The following is a description of a gene set: studied in species Mus musculus Genes predicted to be targets of miRBase v22 microRNA mmu_let_7a_1_3p, mmu_let_7c_2_3p in miRDB v6.0 with MirTarget v4 prediction scores > 80 (high confidence targets). Mouse Gene Set: LET_7A_1_3P_LET_7C_2_3P from publication Chen Y, Wang X (PMID 31504780), and this is the list of marker genes: Zfp518a, Foxp1, Nbea, Cnnm4, Cntrob, Utrn, Srsf2, Sox9, Fbxo38, Il5ra, Usp32 (NCBI Gene Id 77025), Hacd2, Gpalpp1, Etl4, Pabpc4l, Lysmd3, Gp1ba, Gabrg1, Bnip2, Aqr (NCBI Gene Id 99376), Nr2f2, Thrb, Gnpat, Fgfr2, Cnot6l, Mblac2, Myct1, Asic4, Bmpr1a, Kpna3, Kdm7a, Rhot1, Man1a2 (mannosidase, alpha, class 1A, member 2), Plag1, Eea1, Tecrl, Ctu2 (cytosolic thiouridylase subunit 2), Lemd3, Mfsd1, Tns3, Sspn, Mdm4, Klhl2, Fa2h, Slc25a16, Taok1, Glcci1, Sh3gl3, Wdr26, Trpm7, Chd1, Ube2b, Atf2, Cacna2d1, Sp4, Efna5, Dnali1, Pyroxd1, Camta1, Naaladl2, Pcgf5, Ikzf2, Phyhipl, Tusc3, Hdac9, Dock1, Ercc5, Ice1, Hmgxb4, Rsrp1, Itga6, Tmem26, Nr3c1, Zfp318, 9330159F19Rik, Ralgds, Srsf11 (serine and arginine-rich splicing factor 11), Acvr2b, Grk5, Hmgcr, Dock11 (dedicator of cytokinesis 11), Akap1, Mark1, Cftr, Golim4, Foxn2, Acr, Psmd5, Btf3l4, Dll1, Slc18a2 (NCBI Gene Id 68754), Sephs1, Slc6a17, Trpc5, Zfyve21, Bhlhe40, Col4a1, Cdc14b, Gria3, Bmal1, Wnt5a, Fmnl3, Fndc3a, Gata3, Capza2, Oosp1, Sbno1, Mast4, Prkacb, Plcl2, Cdk2ap2, Zfpm2, Cdc42ep3, Cand1, Zic1, Herc2, Pou2af3, Ifit1bl1, Prpf38b, Car10, Itm2c, Tcerg1l, Cdh20, Rb1cc1, Dlx2, Adss2, Usp25, Creld2, Gramd4, Xpo7, Apaf1 (NCBI Gene Id 76129), Mmab, Klhl7, Tra2a, Syt14, Lgr4, Fnip1 (NCBI Gene Id 216742), Ppp1r3b, Arhgap20, Nptn, Ppfia2, Nlgn1, Btg2, Cldn12, Wdhd1, Akap12, Hcrtr2, Dennd2b, Rictor, Bmpr2, Tmem39a, Cadm1, Adcyap1, Pum2, Vkorc1l1, Atad5, Yy1, Calu, Smyd3, Erf, Rab14, Dll4, Lrp6, Jag1, Rif1, Emp2, Bdnf, Ccrl2, Btbd1, Scx, Grm5, Fosl2, Smarca5, Csnk1g3, Mid2, Plk1, Tbc1d4, Mt4, Plekhm3, Spry2, Rnf24, Smo, Sfpq, Tle1, Golga2, Grhl3, Arih1, Nr5a2, Arhgef3, Golga7, Bltp1 (bridge-like lipid transfer protein family member 1), Ubl3, Zmat1, Zmym6, Crk, Rcc1, Tpm1, Scn2a, Pdia3, Nudt4, Ccny, Rnf144a, Aktip, Hhip, Nfat5, Slc25a40, Tubgcp5, D630023F18Rik, Tmtc2, Ppp1r3f, Akap9, Pm20d2, Clspn, Pcdh8, Mbnl2, Il10rb, Prdm16, Ppp1r15b, Tjp1, Jag2, Bnc1, Igf1r, Tcf20, Ppp1r2 (protein phosphatase 1, regulatory inhibitor subunit 2), Tbc1d15, Rnf223, Ccdc126, G2e3, Rfx7, Gulp1, Hectd1 (HECT domain E3 ubiquitin protein ligase 1), Cilk1, Olfml2b, Tab3, AI182371, Gtf2i, Usp12 (NCBI Gene Id 22217), Lin9, Zfp248, Rbm46, Tasor, Skint10, Dmxl2 (Dmx-like 2), Btaf1, Mllt6, Mef2d, Uox, Plppr5, Selenok (selenoprotein K), Btbd3, Cnksr3, Setdb2, Ncapg2, Dcun1d4, Id1 (inhibitor of DNA binding 1, HLH protein), Slc39a10, Lhx5, Psip1, Kcnip2, Rab10, Pias1, Syngr3, Brd1, Mcu, Hycc2, Tle4, Map4, Actr3, Nckap5, Hikeshi, Herc1, Ciart, Mecom, Mdm1 (MDM1 nuclear protein), Myo5a, Scai, Rad21, Rbbp6, Nup35, Frem2, Appl1, Fbxo8, Sfrp2, Ddx21, Zmiz1 (NCBI Gene Id 328365), Myf5, Cpsf6, Armc10 (armadillo repeat containing 10), Zfp704, AI597479, Mycn, Arap2, Col1a2, Tet3, Ormdl1, Add3, Larp4b, Tmem68, Olfm3, Magi1, Tcf3, Cpeb3, Eif4g3, Mycbp2, Ube3c, Syf2, Hivep2, Aak1, Cnr1, Clca3a2, Psd3, Ptbp3, Lats1, Tec (NCBI Gene Id 21682), Rab11fip2, Fli1, Abcb1a, Ubxn7, Kmt2e, Isoc1, Arhgef33, Ppp4r2, Kmt2c, Unc119b, Ssb, Sanbr, Akap6, Zbtb41, Kdm6a, Frs2, Hectd2, Prr12, Klhl24, Zmynd8 (zinc finger, MYND-type containing 8), Rprd1b, Nusap1, Ptms, Ubtf, Dcc, Cnbp, Rasef (NCBI Gene Id 242505), Pcdh11x, Dcaf1, Mllt10, Nfatc3, Gls, Ptpra, Mageb16, Cab39, Cwc22 (NCBI Gene Id 99140), Mycl, Rnf38, Zfp800, Usp31, Col11a1, Nasp, Sall3, Myo9a, Tut4 (NCBI Gene Id 320841), Ebf3, Oxr1, Ubr1, Vezf1, Atp6v1h, Fbxo43, Gng2, Rrm2b, Pde10a, Edil3, Zfp280d, Pik3c2a, Casp8ap2 (NCBI Gene Id 52376), Plekha6, Arhgap44, Rhoa, Kbtbd2, Ripply2, Nudt11 (nudix hydrolase 11), Cnot6, Cpne2, Mex3b, Mitf, Dmtf1, Rev3l, Zfp219 (NCBI Gene Id 69890), Bach2, Arid4b, Cep72, Efcab2, Ccnq, Carmil1, Hnrnpd, Slain2, Dcx, Dcbld2, Ppp1r21, Spen, Snx14, Fbxo34, Atad2, Arfip2, Tm4sf4, Mageb3, Gdap2, Map2, Hip1, Nxt2, Tob1, Zfp101, Ubn1, Zfp850, Septin9, Spata13, Cpeb2, Bdp1, Dennd4a, Hes1, Ncoa2, Klf4, Ptpre, Erbin, Tgfb3, Cry1, Irx3, Txlng, Pafah1b1, Kctd12, Adcy6, Syvn1, Vcf2, Lrp1b, Traf3ip1, Cert1, Wac, Tnfrsf11b, Psd2, Ik, Sde2, Npr3, Npy1r, Cntn1, Wdr35, Sp9, Ppp3ca, Srsf1, Opa1 (OPA1, mitochondrial dynamin like GTPase), Nfkbia, Abcd3, Mon2, Mapk1, Dcaf7, Hbp1, Uty, Col13a1, Spin1, Nexmif (neurite extension and migration factor), Polr2k, Rtn1, Slc10a4, Rab11fip3, Ap1s3, Foxo1, Hook3, Ctla4, Camk2d, Jph1, Mpv17l, Cbx5, Pfkfb3, Tead1, Rcan2, Pnisr, Usp42, Stk40, Acvr1, Thoc1, Rabggtb, Hivep1, Rsf1, S100pbp, Nkiras1 (NCBI Gene Id 69721), Pum1, Gpr37, Foxd3, Basp1, Zcchc24, Spred1 (NCBI Gene Id 99293), Plpp3, Unc79 (NCBI Gene Id 217843), Slc8a1, Med14, Zbtb49, Adamts5, Lrrc1, Rnf170, Ier5, Rab3gap2, Kif11, Fam76b, Rab6b, Fzd6, Spry1, Sgtb, Cacna1b, Crebzf, Rnf115, Zfyve16, Nkx2-9, Myt1l, Npbwr1, Ubn2, Inpp4a, Fabp3, Cecr2, Dgkd, Nphp3 (nephronophthisis 3 (adolescent)), Dach1, Ppp4r3b, Tm7sf3, Pdzrn3, Cul1, Dek, Ythdf3, Eps15l1, Ino80d, Qki, Dcaf6, Snrpb2, Mospd2, Tasp1, Hnrnpa1 (NCBI Gene Id 52621), Paxbp1, Cabp4, Efs, Unkl, Ano4 (anoctamin 4), Fbxo45, Slc20a2, Neurog2, Nktr, Il4, Zbtb14, Bfar, F3, Kdm2b, C1qbp (NCBI Gene Id 28127), Nrp2, Spock3, Ankrd44 (NCBI Gene Id 545320), Slc38a9 (NCBI Gene Id 77071), Mtf1, Rerg, Laptm4a, U2surp, Thbs2